Given this list of marker genes Pramel14, Slc16a6, Ccsap, Lnpk, Dusp10, Zfyve16, Ppfia1, Parp3, Pip4p1, Gpr158, Ppp2r2c, Vash1, Dlg3, Orai2, Col18a1, Cdkal1, Rrbp1, Zcchc2, Nova1, Mynn (myoneurin), Pik3c2a, Cdkn2b, Lratd1, Usp15, Rab1b, Ireb2, Tmc7, Stmn4, Rab35, Slc16a3, Dlg2, Slk, T, Ssr1, Bcl11b, Dnm3, Phldb2, Ptx3, Homer1, Cenpn (NCBI Gene Id 72155), Dnajc28, Rap2a, Rgs16 (regulator of G-protein signaling 16), Ctnnd1, Pmepa1, Phactr2, Tpgs2, Plxna2 (plexin A2), Mapkbp1, Clvs2, Adamts2, Ppp3r1, Cplx2, Slc39a11, Slc44a5, Gng11, Peds1, Stambp, Ints2, Crbn, Eif3a, Tmem9, Rims2, Dram1, Ralgps1, Camk4, Anapc5, Cyp4f14, Hmga2, Ybx2, Sim2, Uba2, Gpatch2l, Arhgef6, Ssr2, Ankrd52, Lrrn1, Psen2, Zfp462, Tfrc, Slc17a6, Atp2b3, Numb, Lypla1, Tmem91, Fxyd6, Prune2, Snap29, Stra6l, Hdlbp, Prkch, Ms4a6c (membrane-spanning 4-domains, subfamily A, member 6C), Zmynd11, Grk6, Cmklr1, Foxn3, Pnisr, Opn5, Pafah2, Gabrb2, Tfdp2, Brd8dc, Mosmo, Zfhx3, Prdm2, Ccdc121rt2, Azi2, Sorcs1, Kcnq5, Vmn2r89, Myot, Psip1, Znfx1, Zfx, Trmt1l, Septin6, Ank3, Cntn1, Rhoq, Peak1, Psmd5, Rabl3, Map3k11, Creg1, 2010003K11Rik, L3mbtl2, Slfn14 (schlafen 14), Tafa1, Gprc5a, Svop (NCBI Gene Id 68666), Arhgap19, Phtf2, Cxcr5, Pappa, Elovl6, Slc5a7, Zdhhc6, Pramel30, Bmal2, Miga1, Spns2, Slc16a1, Picalm, Trpm5, Kcne4, Cplx1, Larp1, Klhl24, AU041133, Sinhcaf, Hecw2, Pex2, Ncs1, Cacna1e, Fmn1, Fam174a, Casp1, Gtf3c4, Nrarp, Abt1, Crybg1, Phf21a, Ropn1l, Aff1, Lmna, Sec11a, Arcn1, Acvr1b, Mgll, Naa30, Mblac2, Cry2, Peli1, Ankzf1, Rhoa, Plekhg3, Arhgef9, Kcnab2, Scn2a, Dpysl3, Tmcc3 (transmembrane and coiled coil domains 3), Epgn, Zpld1, Ctdnep1, Psd3, Tmem255a, Cep164, Marf1 (NCBI Gene Id 98041), Ghsr, Lrrc28, Cacna1d, Rchy1 (ring finger and CHY zinc finger domain containing 1), Rgs17, Scn3b, here is a description of the gene set: Mouse Gene Set: MIR_7002_5P from publication Chen Y, Wang X (PMID 31504780) Genes predicted to be targets of miRBase v22 microRNA mmu_miR_7002_5p in miRDB v6.0 with MirTarget v4 prediction scores > 80 (high confidence targets). studied in species Mus musculus